Given this list of marker genes HDAC9, MYOD1, MYOG, SHOX2, LMOD3, FBXO22, BCL2, NACA, MYF6, ACTN3, MYF5, here is a description of the gene set: Human Gene Set: GOBP_REGULATION_OF_SKELETAL_MUSCLE_FIBER_DEVELOPMENT Any process that modulates the frequency, rate or extent of skeletal muscle fiber development. Muscle fibers are formed by the maturation of myotubes. They can be classed as slow, intermediate/fast or fast. species: Homo sapiens